The following is a description of a gene set: Reactome Pathway: APC/C:Cdc20 mediated degradation of mitotic proteins species: Homo sapiens part of: Activation of APC/C and APC/C:Cdc20 mediated degradation of mitotic proteins Following phosphorylation of the APC/C core subunits by mitotic kinases, the activating protein, Cdc20 is recruited to the APC and promotes the multiubiquitination and subsequent degradation of the mitotic cyclins (Cyclin A and Cyclin B) as well as the protein securin which functions in sister chromatid cohesion. Timely degradation of these proteins is essential for sister chromatid separation and the proper timing of exit from mitosis (See Zachariae and Nasmyth, 1999). Cdc20 is degraded late in mitosis (Reviewed in Owens and Hoyt, 2005), and this is the list of marker genes: ANAPC10, RPS27A, CDK1, PSMA7, ANAPC4, UBE2S, ANAPC7, ANAPC16, ADRM1, PSMD8, CCNA1, CDC23, CDC26, UBA52, PSMD6, ANAPC15, PSMD1, PSMC3, UBE2E1, NEK2, BUB1B, PSMA4, PSMB1, CDC16, ANAPC1 (NCBI Gene Id 64682), PSMD13, PSMA5, PSMC6 (proteasome 26S subunit, ATPase 6), PSMC5, ANAPC2, PSMA3, PSMA1, PSMB2, PSMD14, PSMA2, UBE2C, PSMB7, PSMA6, ANAPC11, PSMC2, UBC, PSMB6 (proteasome 20S subunit beta 6), PSMD3, SEM1, PSMD7, PSMB5, PTTG1, CCNB1, CDC20 (NCBI Gene Id 991), PSMB4, PSMD2, PSMB3, PSMD11, MAD2L1, BUB3, PSMC1, ANAPC5, UBE2D1, PSMC4, UBB, CDC27, PSMD12, CCNA2